The following is a description of a gene set: studied in species Mus musculus This event has been computationally inferred from an event that has been demonstrated in another species.<p>The inference is based on the homology mapping from PANTHER. Briefly, reactions for which all involved PhysicalEntities (in input, output and catalyst) have a mapped orthologue/paralogue (for complexes at least 75% of components must have a mapping) are inferred to the other species. Reactome Pathway: Protein localization electronically inferred by orthology from the curated human pathway, and this is the list of marker genes: Hspd1, Acox2, Decr2, Dao, Pxmp2, Amacr, Vapa, Dhrs4, Baat, Pex19, Ehhadh (enoyl-Coenzyme A, hydratase/3-hydroxyacyl Coenzyme A dehydrogenase), Abcd1, Sec61b, Pipox (pipecolic acid oxidase), Acot2, Otc, Ube2d1, Acaa1b, Coq2, Pex1, Gdap1, Pex11b, Atad1, Acot5, Hsd17b4, Fis1, Hao1, Ndufb8, Crot, Fxn, Eci2, Stx1a (NCBI Gene Id 20907), Acot8 (acyl-CoA thioesterase 8), Pex13, Vamp2, Acot3 (acyl-CoA thioesterase 3), Acot4, Pex5, Pex12, Ubb, Emd, Rps27a, Tysnd1, Acbd5, Acox3 (acyl-Coenzyme A oxidase 3, pristanoyl), Pex7, Sec61g, Pex26, Atp5f1b, Slc27a2, Serp1, Pitrm1, Abcd2, Ech1, Mlycd, Nos2, Ephx2, Mpv17, Lonp2